The following is a description of a gene set: Multiple myeloma (MM) is the most common form of plasma cell dyscrasia, characterized by a marked heterogeneity of genetic lesions and clinical course. It may develop from a premalignant condition (monoclonal gammopathy of undetermined significance, MGUS) or progress from intramedullary to extramedullary forms (plasma cell leukemia, PCL). To provide insights into the molecular characterization of plasma cell dyscrasias and to investigate the contribution of specific genetic lesions to the biological and clinical heterogeneity of MM, we analysed the gene expression profiles of plasma cells isolated from seven MGUS, 39 MM and six PCL patients by means of DNA microarrays. MMs resulted highly heterogeneous at transcriptional level, whereas the differential expression of genes mainly involved in DNA metabolism and proliferation distinguished MGUS from PCLs and the majority of MM cases. The clustering of MM patients was mainly driven by the presence of the most recurrent translocations involving the immunoglobulin heavy-chain locus. Distinct gene expression patterns have been found to be associated with different lesions: the overexpression of CCND2 and genes involved in cell adhesion pathways was observed in cases with deregulated MAF and MAFB, whereas genes upregulated in cases with the t(4;14) showed apoptosis-related functions. The peculiar finding in patients with the t(11;14) was the downregulation of the alpha-subunit of the IL-6 receptor. In addition, we identified a set of cancer germline antigens specifically expressed in a subgroup of MM patients characterized by an aggressive clinical evolution, a finding that could have implications for patient classification and immunotherapy. from publication Mattioli M, Agnelli L, Fabris S, Baldini L, Morabito F, Bicciato S, Verdelli D, Intini D, Nobili L, Cro L, Pruneri G, Callea V, Stelitano C, Maiolo AT, Lombardi L, Neri A (PMID 15735737) Human Gene Set: MATTIOLI_MGUS_VS_PCL Genes changed in MGUS (monoclonal gammopathy of undetermined significance) compared to PCL (plasma cell leukemia) samples. species: Homo sapiens, and this is the list of marker genes: HECA, IGKV1OR2-108, NUP62, IGHV3-21, MAP4K1, NSD2, PLPP3, SAC3D1, IGKV1D-8, PCNA, MSH6, SMARCA4 (SWI/SNF related, matrix associated, actin dependent regulator of chromatin, subfamily a, member 4), CCT4, ACTR3, WDR18, IGKV1D-37, IGKV4-1, LPCAT4, SSR4, TUBB, IGKV1D-17, IGHG1, ELANE, CPQ, B2M, PRDX3, DEFA1, PFN1, RBM10, IGHV3-33, IGLC2, UBA1 (ubiquitin like modifier activating enzyme 1), EEF1A1, HNRNPF, MCM4, ENO1, AP3D1, PPBP, IGHV3-72 (immunoglobulin heavy variable 3-72), CCNL1, PSMA3, SNRPD3, SAP30, CKS1B, TUBA1B, LST1, CDC73, MCM2 (minichromosome maintenance complex component 2), ABCE1, IGKV1D-13, ITPA, IGKV1D-39, NUSAP1 (NCBI Gene Id 82534), XPO1, IGLV3-19, LAPTM4B, CCT3, TUBA1A, IGHV3-20, IGHV3-7, IGLV2-14, IGHV4-34, RPLP1, G3BP1 (G3BP stress granule assembly factor 1), LILRB1 (leukocyte immunoglobulin like receptor B1), TBCB, CAD, JUNB, IGKV2D-28, IGLV3-25, PSMC4, RRP9, PRTN3, DDX39B, AKAP1, GADD45B, NASP, MCM6, EXOSC2, STAP1, ESYT1, CD74, KIF21B, FADD, CSTF2T, NUP210, RNASE3, PAICS, TBRG4, EXOSC4, CORO1A, JPT2, RGCC, SMC1A, JUND, PELI1, RUVBL1, ASF1A, PPP1R15A, ENSG00000301105, SLAMF1, MRPL58, SHQ1, CSNK2A1, RMDN1, LBR, RPS6, PSMD4, S100A8, MCM5, SRSF1, IGLV4-60 (immunoglobulin lambda variable 4-60), SNRPF, HBA1, RAN, EPAS1, CXCL8, IGLV3-10, SEPHS1, CPNE3 (NCBI Gene Id 8895, copine 3), IGHV3-23, PARP1, IGHV4-61, IGKV1OR1-1, TPT1, IGHV1-69, INTS7